The following is a description of a gene set: electronically inferred by orthology from the curated human pathway Reactome Pathway: Gap-filling DNA repair synthesis and ligation in GG-NER species: Mus musculus This event has been computationally inferred from an event that has been demonstrated in another species.<p>The inference is based on the homology mapping from PANTHER. Briefly, reactions for which all involved PhysicalEntities (in input, output and catalyst) have a mapped orthologue/paralogue (for complexes at least 75% of components must have a mapping) are inferred to the other species. part of: Global Genome Nucleotide Excision Repair (GG-NER), and this is the list of marker genes: Polk, Rps27a, Rfc1, Rfc3 (NCBI Gene Id 69263), Rpa1, Pcna, Pold2, Pold4, Pole2, Ubb, Pole, Pold1